Given this list of marker genes ATP9A, CTNND2, RTN1, WDR47, TRIM2, ADCY1, FXYD6, ASTN1, SOBP, ANK2, SNAP91, CSPG5, GNAO1, RALYL, KIF5C, YWHAH, NAP1L3, INA, TMEM35A, GABBR2, SRGAP2, DOCK3, NRXN1, CDK5R1, CLIP3, NMNAT2, GPM6A, RGS7, GDI1, SCN3B, KCNQ2, NCAN, DYNC1I1, KIF1B, KIF3C, ACTRT1, MAPT, RFPL1S, GAP43, DCLK1, TUBB, CAMK2N1, STXBP1, GAD1, C14orf132, FAM131B, ADGRB3, MYT1L, STMN4, MLLT11, NRXN2, DNAJC6, here is a description of the gene set: species: Homo sapiens Human Gene Set: GNF2_RTN1 Neighborhood of RTN1 Neighborhood of RTN1 reticulon 1 in the GNF2 expression compendium